Given this list of marker genes HLA-DQB1, IFI30, CXCL10, TMSB10, PSME2, HLA-B, HLA-DPB1, CXCL3, CXCL11, LCN2, LTF, HLA-DPA1, REG3A, CXCL9, CXCL2, ID1, DUOX2, ALDH2, SAT1, RGS5, HLA-DRB1, ANXA10, UBD, TYROBP, SULT1C2, KCNE3, IFITM3, FAM3D, HLA-DMA, HSPA8, BIRC3, PIGR, HLA-A, B2M, IFI27, STAT1, HLA-DQA1, SOD2, HLA-DRA, VNN2, CD24, CD74, REG1A, WARS1, here is a description of the gene set: Human Gene Set: BUSSLINGER_GASTRIC_REG3A_POSITIVE_CELLS species: Homo sapiens from publication Busslinger GA, Weusten BLA, Bogte A, Begthel H, Brosens LAA, Clevers H (PMID 33691112)